Given this list of marker genes RB1, TSKU, MIR98, PARP1, PDCD4, MIR27B, MIR21, TP53INP1, MIR9-1, FOSL2, here is a description of the gene set: Human Gene Set: GOBP_REGULATION_OF_MYOFIBROBLAST_DIFFERENTIATION Any process that modulates the frequency, rate or extent of myofibroblast differentiation. species: Homo sapiens